The following is a description of a gene set: Human Gene Set: chr2p24 species: Homo sapiens, and this is the list of marker genes: RPS25P3, ENSG00000294705, PSMC1P10, LINC01808, RN7SKP27, RNU5E-7P, RPLP1P5, RNU6-1288P, KCNS3, WDR35-DT, RPS26P18, NDUFAF2P1, RNU6-961P, LINC00954, HS1BP3-IT1, RN7SL104P, LINC00276, MYCNOS, SLC7A15P, NBAS, LAPTM4A, SMC6, NT5C1B-RDH14, MIR3681, MIR4757, KLHL29 (kelch like family member 29), LINC01884, OSR1, LINC02923, LINC01376, VSNL1, SNORD18, APOB, HS1BP3, RNU6-843P, GEN1, RN7SL117P, ENSG00000231204, LINC01830, LRATD1, LINC02850, RDH14, ENSG00000234022, ENSG00000238371, TTC32-DT, ENSG00000300555, LAPTM4A-DT, RNA5SP87, RHOB, MIR3125, MSGN1, LINC03116, CYRIA, LINC01822, DDX1, RNA5SP86, MYCNUT, TRIB2, RNU7-113P, NUTF2P8 (nuclear transport factor 2 pseudogene 8), LINC01866 (long intergenic non-protein coding RNA 1866), PUM2, RPS16P2, GACAT3, TTC32, RNU6-1215P, WDR35, ZFYVE9P2 (NCBI Gene Id 100420972), CISD1P1, RN7SL140P, TDRD15, DRG1P1, GDF7, SDC1, MATN3, ENSG00000225649, MYCN, ENSG00000212455, LDAH, RN7SKP168, RAD51AP2, LINC01804, NT5C1B